The following is a description of a gene set: Pathway Definition from KEGG: E7 -> (CCNE+CDK2) -> RB1 // E2F studied in species Homo sapiens Human Gene Set: KEGG_MEDICUS_PATHOGEN_HPV_E7_TO_P27_CELL_CYCLE_G1_S HPV E7 to p27-cell cycle G1/S. Pathway ID: N00360. Pathway type: Pathogen. Pathway class: nt06166 Human papillomavirus (HPV)., and this is the list of marker genes: E2F2, CCNE2, CDK2, E2F1, RB1, CCNE1, E2F3